Given this list of marker genes Fdxr, Stard6, Cyp11a1, Tspoap1, Stard3nl, Star, Stard4, Fdx2, Akr1b1, Stard3, Tspo, Fdx1, here is a description of the gene set: species: Mus musculus Pregnenolone biosynthesis Mouse Gene Set: REACTOME_PREGNENOLONE_BIOSYNTHESIS